Given this list of marker genes H2AX, CBX3, MDC1, ATR, ATM, RNF168, NIPBL, RNF8, here is a description of the gene set: NIPBL role in DNA damage - Cornelia de Lange syndrome studied in species Homo sapiens Human Gene Set: WP_NIPBL_ROLE_IN_DNA_DAMAGE_CORNELIA_DE_LANGE_SYNDROME